The following is a description of a gene set: species: Homo sapiens Reactome Pathway: Defective CBLIF causes IFD Defects in cobalamin binding intrinsic factor CBLIF, aka gastric intrinsic factor GIF) cause hereditary intrinsic factor deficiency (IFD, aka congenital pernicious anemia; MIM:261000). IFD is an autosomal recessive disorder characterized by megaloblastic anemia. part of: Defects in cobalamin (B12) metabolism, and this is the list of marker genes: CBLIF